The following is a description of a gene set: The chemical reactions and pathways involving purine nucleoside monophosphate, a compound consisting of a purine base linked to a ribose or deoxyribose sugar esterified with phosphate on the sugar. studied in species Homo sapiens Human Gene Set: GOBP_PURINE_NUCLEOSIDE_MONOPHOSPHATE_METABOLIC_PROCESS, and this is the list of marker genes: ADSL, ADSS2, DLG1, GMPS, GDA, PFAS, AK1, XDH, AK4, AK3, CARD11, AMPD1, MAGI3, MPP1, PRTFDC1, DNPH1, AMPD3, LRGUK, NT5C (NCBI Gene Id 7370), PAICS, IMPDH1, APRT, ADK, NUDT2, AK2, ADSS1, DLG2, TJP2, AMPD2, GMPR2, DCK, GUK1, DGUOK, PPAT, ADA, NT5E, HPRT1, GART, IMPDH2, CASK, ATIC, NT5C1A, PNP, NT5C2